Given this list of marker genes ZEB2, LRP1, ADORA2A, IFNGR1, GRN, MIR181B1, CNTF, TREM2, LDLR, TTBK1, NAGLU, IL6, MAPT, APP, C5AR1, PSEN1, IL1B, C1QA, SMO, AGER, NR1D1, MIR142, IFNG, MIR181C, FPR2, TNF, here is a description of the gene set: Human Gene Set: GOBP_ASTROCYTE_ACTIVATION A change in morphology and behavior of an astrocyte resulting from exposure to a cytokine, chemokine, cellular ligand, or soluble factor. studied in species Homo sapiens